Given this list of marker genes IGF1, IGFBP6, IGFBP5 (insulin like growth factor binding protein 5), IGFALS, IGFBP3, here is a description of the gene set: studied in species Homo sapiens A complex of proteins which includes the insulin-like growth factor (IGF) and a number of IGF-binding proteins. The complex plays a role in growth and development. Human Gene Set: GOCC_INSULIN_LIKE_GROWTH_FACTOR_BINDING_PROTEIN_COMPLEX